The following is a description of a gene set: Reactome Pathway: Defective RFT1 causes CDG-1n part of: Diseases associated with N-glycosylation of proteins The N-glycan precursor is flipped across the ER membrane, moving it from the cytosolic side to the ER lumenal side. The exact mechanism of this translocation is not well understood but protein RFT1 homolog (RFT1) is known to be involved. Defects in RFT1 are associated with congenital disorder of glycosylation 1n (RFT1-CDG, CDG-1n). The disease is a multi-system disorder characterised by under-glycosylated serum glycoproteins. Early-onset developmental retardation, dysmorphic features, hypotonia, coagulation disorders and immunodeficiency are reported features of this disorder. studied in species Homo sapiens, and this is the list of marker genes: RFT1